The following is a description of a gene set: species: Homo sapiens part of: Host Interactions of HIV factors Vpr has been implicated in multiple processes during HIV-1 replication, including nuclear import of the pre-integration complex (PIC), apoptosis and induction of cell cycle G2/M arrest.<br><br> Interactions between Vpr and host nucleoporins (importin) appear to facilitate the nuclear import of the PIC while interactions between Vpr the adenine nucleotide transporter (ANT) protein at the inner mitochondrial membrane may contribute to release of apoptosis factors by promoting permeabilization of the mitochondrial outer membrane. <br> <br>Vpr induces cell cycle G2/M arrest by promoting hyperphosphorylation of Cdk1/Cdc2. However, it is unclear which protein(s) Vpr interacts with to cause this effect. For recent reviews, see,. Progression of cells from G2 phase of the cell cycle to mitosis is a tightly regulated cellular process that requires activation of the Cdk1/Cdc2 kinase, which determines onset of mitosis in all eukaryotic cells. The activity of Cdk1/Cdc2 is regulated in part by the phosphorylation status of tyrosine 15 (Tyr15) on Cdk1/Cdc2, which is phosphorylated by Wee1 kinase during late G2 and is rapidly dephosphorylated by the Cdc25 tyrosine phosphatase to trigger entry into mitosis. These Cdk1/Cdc2 regulators are the downstream targets of two well-characterized G2/M checkpoint pathways which prevent cells from entering mitosis when cellular DNA is damaged or when DNA replication is inhibited. It is clear that Vpr induces cell cycle G2/M arrest by promoting Tyr15 phosphorylation of Cdk1/Cdc2 both in human and fission yeast cells, which modulates host cell cycle machinery to benefit viral survival or replication. Although some aspects of Vpr-induced G2/M arrest resembles induction of host cellular checkpoints, increasing evidence suggests that Vpr induces cell cycle G2 arrest through a mechanism that is to some extent different from the classic G2/M checkpoints. One the unique features distinguishing Vpr-induced G2 arrest from the classic checkpoints is the role of phosphatase 2A (PP2A) in Vpr-induced G2 arrest (Elder, Benko, and Zhao, 2002; Elder et al., 2001; Masuda et al., 2000). Interestingly, PP2A is targeted by a number of other viral proteins including SV40 small T antigen, polyomavirus T antigen, HTLV Tax and adenovirus E4orf4. Thus an in-depth understanding of the molecular mechanisms underlying Vpr-induced G2 arrest will provide additional insights into the basic biology of cell cycle G2/M regulation and into the biological significance of this effect during host-pathogen interactions. Reactome Pathway: Interactions of Vpr with host cellular proteins, and this is the list of marker genes: PSIP1, rev, NUP153, AAAS, POM121C, NUP160, SEC13, gag, NDC1, NUP205, RANBP2, NUP107, NUP93, BANF1, TPR, HMGA1, NUP155, NUP62, vpu, NUP85, NUP98, NUP42, NUP54, gag-pol, NUP58, NUP133, NUP214, NUP50, SLC25A6, SLC25A4, SEH1L, vif, POM121, NUP188, NUP210, SLC25A5, NUP37, vpr, NUP88, NUP35, NUP43, RAE1, KPNA1